The following is a description of a gene set: species: Mus musculus Mouse Gene Set: REACTOME_EICOSANOIDS Eicosanoids, and this is the list of marker genes: Tbxas1, Cyp4a12a, Cyp4f18, Cyp4b1, Cyp4a10, Cyp4a32, Cyp4f14, Cyp4a29, Cyp4f40, Cyp4f15, Cyp4a30b, Cyp8b1, Cyp4f39, Cyp4a12b, Cyp4a14, Cyp4a31 (cytochrome P450, family 4, subfamily a, polypeptide 31), Ptgis